The following is a description of a gene set: studied in species Mus musculus Genes positively differentially expressed in cell type: Langerhans upon treatment with cytokine: IL-18 in mouse lymph nodes in vivo. Mouse Gene Set: CUI_LANGERHANS_IL18_RESPONSE_UP from publication Cui A, Huang T, Li S, Ma A, Pérez JL, Sander C, Keskin DB, Wu CJ, Fraenkel E, Hacohen N (PMID 38057668) Cytokines mediate cell-cell communication in the immune system and represent important therapeutic targets. A myriad of studies have highlighted their central role in immune function, yet we lack a global view of the cellular responses of each immune cell type to each cytokine. To address this gap, the authors created the Immune Dictionary, a compendium of single-cell transcriptomic profiles of more than 17 immune cell types in response to each of 86 cytokines (>1,400 cytokine-cell type combinations) in mouse lymph nodes in vivo. A cytokine-centric view of the dictionary revealed that most cytokines induce highly cell-type-specific responses. For example, the inflammatory cytokine interleukin-1β induces distinct gene programmes in almost every cell type. A cell-type-centric view of the dictionary identified more than 66 cytokine-driven cellular polarization states across immune cell types, including previously uncharacterized states such as an interleukin-18-induced polyfunctional natural killer cell state., and this is the list of marker genes: Kdm6a, Nfil3, Cd302, Jaml, Ikzf1, Suv39h2, Cmtm6, Glipr2, Pnkd, Trip12, H1f10 (H1.10 linker histone), Rap2a, Bcl2a1a, Acsl5, Gclc, Ly75, Il10ra, Rars1, Rab30, Nrp2, Mfhas1, Vim, Iigp1, Nr4a3, Timm44, Tab2, Malt1, Adra1a, Mab21l3, Irf5, Cxcl10, Cd86, Prdm1, Scn3a, Atp6v0a1, Tcaf2, Tcaf1, Vdr, Bcl2a1b, Ndufab1, Ifi47, Ncoa7, Etnk1, Lima1, Olfm1, Orai1, Slc33a1, Ntmt1, Ctsc, Crem, Ldha (NCBI Gene Id 16828), Pdlim5, St8sia4, Ktn1, Ehd1, Fgl2, Zbp1, Pdcd1lg2, Auh, Ppa1, Gtf2b, Ikzf4, Plk2, Psen2, Ggta1, Bcl2a1d, Irf9, Plek2, Cxcl9, Cd274, Gpr141, Napsa, Avl9, Krcc1, Diaph1, Xbp1, Hnrnpk, Isg15, Plgrkt, Mir155hg (Mir155 host gene (non-protein coding)), Casp4, Anxa5, Traf5, Ocln, Socs1, Ifi35, Atp6ap2, Stat1, Socs2, Bzw1, Uri1, Irgm1, Rbbp4, Wars1, Serpina3g (serine (or cysteine) peptidase inhibitor, clade A, member 3G), Macroh2a1 (macroH2A.1 histone), Nup88, Lipe, Mdfic, Faf1, Coro2a, Litaf, Prps1, Necap2, Vopp1, Ccdc25, Tap1, AI987944, Gpbp1, Mylk, Parp9, Irf1, Irgm2, Jak2, Uap1, Adgrg6, Slfn2, Cyrib, Cish, Samhd1, Ndrg1, Zfand6, Gbp3, Pkib, Fam98c, Igtp, Gbp2, Cst3, Psmb5, Cdkn1a, Cox18, Rnf31, Adgre5, Ptpn1, Chd7, Prpf31, Pim1, Pfdn2, Sft2d2, Ccl17, Mat2a, Eif3a, Pnp, Nae1, Cd48, Nckap1l, Bcl2l11, Sike1, Basp1, Gbp5, Cyp51, Cyfip1, Pcyt1a, Atrx, Akt3, Aff1